Given this list of marker genes MBD3L3, MECP2, MBD3 (NCBI Gene Id 8931), CHTOP, MBD3L2B, TET1, UHRF1, CDX2, PRMT1, PRMT5, MBD1, ZBTB38, MBD2, DNMT1, WDR77, LHX4, MBD3L1, MBD3L5, ZBTB21, MBD3L4, ZBTB4, ERH, TET3, CXXC4, MBD3L2, ZBTB33, CXXC5, HOXB13, LRWD1, CDX1, here is a description of the gene set: Human Gene Set: GOMF_METHYL_CPG_BINDING species: Homo sapiens Binding to a methylated cytosine/guanine dinucleotide.